Given this list of marker genes MEN1, PTEN, KRAS, HRAS, EPCAM, PIK3CA, PMS2, MLH1, IFNG (NCBI Gene Id 3458), KRT17 (keratin 17), SDHB, NRAS, TSC1, KLLN, SEC23B, PMS1, AKT1, TGFBR2 (transforming growth factor beta receptor 2), TSC2, SDHC, MSH2, SDHD, MSH6, PLCD1, USF3, here is a description of the gene set: Adenoma sebaceum Human Gene Set: HP_ADENOMA_SEBACEUM The presence of a sebaceous adenoma with origin in the sebum secreting cells of the skin. studied in species Homo sapiens